The following is a description of a gene set: Human Gene Set: GOCC_SPINDLE studied in species Homo sapiens The array of microtubules and associated molecules that forms between opposite poles of a eukaryotic cell during mitosis or meiosis and serves to move the duplicated chromosomes apart., and this is the list of marker genes: ANAPC5, SAC3D1, CEP250, NSUN2, CDC25B, E4F1, HAUS2, CALM2, MTCL1, MAP7D1, SGO1, RTRAF, CLASP1, JTB, PKD2, UBXN2B, FBXO5, DCTN1, FMN2, CLASP2, ATAT1, MAPK15, SEPTIN2, SPIN1, HSPA2, KIF15, SPAG8, SPAG5, ANKFN1, PYCR3 (NCBI Gene Id 93098), KIF14, BIRC5, NSL1, TOPBP1, CHMP7, KNSTRN, BBLN, CEP19, CHMP4BP1, KIF3A, SKA3, DIDO1, TPT1, KAT5, LATS1, DYNC2I1, KAT2B, CHAMP1, KIF2C, AURKA, ARHGEF7, TUBB8B, PMF1, CTTN, TUBG2, AGBL5, CEP104, GEM, GPX2, KIF20B, PPP2CB, MAD2L1, TOPORS, TRAPPC14, AAAS, CBX3, ALMS1, RSPH1, KASH5, POC1B, RAB24, KIF2B, FAM83D, CAPN6, TBCK, CSNK1D (casein kinase 1 delta), AFG2B, AFG2A, CEP170, IKBKG, ALPK1, CEP44, KAT2A, DYNC1LI1, AURKC, TUBGCP3 (NCBI Gene Id 10426), MZT1, MAPK1, EMD, NGRN, CSNK1A1, OR2A4, CIAO1, SMC1A, UHRF1, MAD2L1BP, ZZZ3, TUBG1, AURKB, FBF1, BCL2L10, NCOR1, TNKS, TUBB2B, CCDC117, VPS4A, WDR5, HAUS6 (NCBI Gene Id 54801), ARL2BP, KMT5B, KIF18A, RPS3, KIFC1, KATNB1, HMMR, CBX1, NPM1, RGS14, HSF1, MID1, INCENP, PTPN7, CEP295, CFAP53, AKT1, HSPB1, ANXA11, IK, SPESP1, TBL1X, TMEM9, MYC, SKA1, CTDP1, GIT1, KATNBL1, LUZP1, CIAO2B, MAPRE1, PARP4, CDC20 (cell division cycle 20), ECT2, CYLD, DSN1, CNTRL, KLHL21, CCNB1, EPB41, TMEM201, FRY, SBDS, MAD1L1 (mitotic arrest deficient 1 like 1), NDEL1, TRIM75, RCC2, DNAAF1 (dynein axonemal assembly factor 1), HDAC3, KIFAP3, FLCN (folliculin), HEPACAM2, PLK2, BIRC6 (NCBI Gene Id 57448), UNC119, CHMP4C, DR1, NEK2, TAF1D, SMC3, TUBB, RACGAP1, CHMP5, UMOD, LATS2 (NCBI Gene Id 95108), NDE1, ABRAXAS2, HECW2, MIS12, CEP85, DNALI1, NEIL2, LSM14A, AUNIP, BCCIP, CD180, ODAM, PLK3, PTP4A1, ZWILCH, NUDC, RB1, RMDN1, KAT14, DYNLT1, CCDC69 (NCBI Gene Id 26112), USP44, CDC14A, TBCCD1, TADA2A, SKA2, NUP62, NEK6, MISP, MAEA, STAG1, KIF16B, WAPL, NUMA1, PLK5, MAP2K5, TRAT1, DIAPH1, CDC42, SPOUT1, UXT, RIF1, TERF1, YPEL5, WNK1, CHMP4A, RASSF1, CDC14B (NCBI Gene Id 8555), KIF3B, CXCR2, BNIP2, INVS, RAD21, MBIP, MTUS1, RMDN2, CKAP5, TUBB1, TTC28, EFHC1, KLHL22, CHMP2B, ESPL1, ARHGEF2, NUP85 (nucleoporin 85), CDCA8, CHMP3, ENKD1, ODF2, RAB11A, TBL1XR1, NEK7, KLHL42, FAM110C, CHMP4B (charged multivesicular body protein 4B), CDK5RAP2, ARL8A, TUBGCP4, MAP1S, MAP9, ACOT13, MAPRE2, ASPM, HNRNPU (NCBI Gene Id 3192), DCTN4, MMS19, RASSF10, ZNF207, FAM110A, CHMP1A, SPDL1, MZT2B, GPSM2, NEDD1, MAPKBP1, HAUS3, YEATS2, TUBB2A, CCDC66, KIF22, HNF4G, CETN1, HASPIN, DYNLT2B, PKP4, MAPRE3, CAPG, TUBB8, SIRT2, MYF6, CLTC, NR3C1 (NCBI Gene Id 389335), CHMP1B, CCDC57, CDC14C, PIN4, TTL, LEMD2, MYH10, SEPTIN6, KIF4A, SPICE1, TPX2, RAB11FIP4, POLB, CENPV, RALBP1, CCSAP, DYNC1I1 (dynein cytoplasmic 1 intermediate chain 1), RMDN3, NSMCE1 (NCBI Gene Id 197370), CSPP1, SHCBP1L, CDC6, PLK1 (NCBI Gene Id 5347), HAUS4, PPP2CA, RAE1, NIN (ninein), CLTA, TUBB6, TPR, ARL3, SLC25A5, HAUS5, NUDCD2, CSAG1, GOLGA2, MICAL3, CENPE, PKHD1, IRAG2, CKAP2L (NCBI Gene Id 150468), EVI5, CALM1, TUBGCP5, NUSAP1, CEP95, DIAPH3, ANKRD53, DLGAP5, LIMK2, IFT88, DYNLL1, FIRRM, STX1B, CHMP2A, POC1A, ARHGAP6, KATNAL2, PAFAH1B1, FAM161A, POLDIP2 (NCBI Gene Id 26073), CCAR2, NME7, KIF2A, TUBGCP6, CALM3, MAPK14, TUBB4B (tubulin beta 4B class IVb), KATNAL1, CHMP6, EML3, KIF20A, ATM, DCTN3, STAG2, TPPP, PSRC1, RANGAP1, SGF29, INO80, CDC27, KBTBD8, RPS6KA2, MAP10, SEPTIN12, MAP7D3, EML2, CEP350, HAUS8, SMC6 (structural maintenance of chromosomes 6), SNCG, TADA3 (NCBI Gene Id 10474), DYNLT3, ARL8B, DNAAF5, KIF18B, INPPL1, CTNNB1, SPECC1L, CRMP1, SEPTIN7 (NCBI Gene Id 989), KIF11, DCDC1, CUL3, MYH9, TTLL12, CEP162, NUBP2, CDC7, KIF23, KATNA1, BRCC3, BOD1, CEP89, PRPF19, TUBB4A, WDR73, PRC1, ADRB2, MAK, PLEKHG6, BORA (NCBI Gene Id 79866), KNTC1, ERCC2, TUBGCP2, SHCBP1, HAUS7, PHLPP2, NEDD9, IFT43, DCUN1D5, CKAP2, CDK1, TACC3, TFDP2, CEP128, BEX4, PINX1, DAPK3, KPNA7, MZT2A, CLTCL1, SEPTIN1, BUB1B, TTC23L, ZW10, DPYSL2, TTK, ANAPC7, EML4, CENPF, SPAST, CEP63, EML1, WDR62, HAUS1 (NCBI Gene Id 115106), DZIP1L, DDX11, MAP4, VPS4B, MAD2L2, SLC34A1, TUBB3, CDC16